Given this list of marker genes FKBP1B, SLC8A2, STIM1, ATP1A3, ITPR2, ASPH, FXYD4, RYR1, DMPK, SLN, ATP2B4, CAMK2D, ORAI1, ABCC9, ATP1B1, ATP1A4, SRI, ITPR3, ORAI2, RYR3, FXYD7, PRKACA (NCBI Gene Id 5566), ATP1A1, TNNI3, ATP2B2, FXYD1, ATP1A2, RYR2, ATP2B3, CAMK2G, PLN, ITPR1, CAMK2B, KCNJ11, TRPC1, TRDN, CASQ2, AHCYL1, ATP2B1, CLIC2, FXYD6, NOS1, ATP2A1 (ATPase sarcoplasmic/endoplasmic reticulum Ca2+ transporting 1), FXYD3, ATP2A2, SLC8A3, SLC8A1, CALM1, CASQ1, CAMK2A, FXYD2, ATP2A3, ATP1B2, ATP1B3, here is a description of the gene set: Ion homeostasis Human Gene Set: REACTOME_ION_HOMEOSTASIS species: Homo sapiens